Given this list of marker genes TXN (NCBI Gene Id 7295), FOXO1, SIRT1, CREBBP, KAT2B, EP300 (E1A binding protein p300), FOXO4, SIRT3, FOXO3, TXNIP, here is a description of the gene set: Reactome Pathway: Regulation of FOXO transcriptional activity by acetylation species: Homo sapiens part of: FOXO-mediated transcription Oxidative stress induces acetylation of FOXO transcription factors, which changes the preference of FOXO transcription factors for target DNA sequences. Histone deacetylases SIRT1 and SIRT3 deacetylate FOXO transcription factors.<br>Acetylation can also regulate FOXO localization, overriding phosphorylation.